The following is a description of a gene set: Mitochondrial depletion Human Gene Set: HP_MITOCHONDRIAL_DEPLETION An abnormal reduction in mitochondrial DNA content of cells. studied in species Homo sapiens, and this is the list of marker genes: TFAM, POLG, OPA1, RRM1, TYMP, MGME1, TTN, ATP5F1A, SLC25A4, FBXL4, SUCLG1, RRM2B, MPV17, TOP3A, DGUOK (NCBI Gene Id 1716), NEB, LIG3, TWNK, DNA2, TK2, SLC25A10, AGK, POLG2